Given this list of marker genes Tgif1, Tfdp1, Rnf111, Atp1b4, Wwtr1, Cdk8, Mapk3, Smurf2, Ube2d1, Ncor2, Rps27a, Ubb, Men1, Smad3, Smad7, Snw1, here is a description of the gene set: electronically inferred by orthology from the curated human pathway This event has been computationally inferred from an event that has been demonstrated in another species.<p>The inference is based on the homology mapping from PANTHER. Briefly, reactions for which all involved PhysicalEntities (in input, output and catalyst) have a mapped orthologue/paralogue (for complexes at least 75% of components must have a mapping) are inferred to the other species. Reactome Pathway: Transcriptional activity of SMAD2/SMAD3:SMAD4 heterotrimer studied in species Mus musculus part of: Generic Transcription Pathway; Signaling by TGF-beta Receptor Complex